The following is a description of a gene set: studied in species Homo sapiens The process whose specific outcome is the progression of the otolith over time, from its formation to the mature structure. Human Gene Set: GOBP_OTOLITH_DEVELOPMENT, and this is the list of marker genes: NOX3, LRIG1, ATG4B, SLC44A4, OTOL1, LRIG3, ATG5, OC90, BLOC1S5, TTC39C